Given this list of marker genes Kcnb1 (potassium voltage gated channel, Shab-related subfamily, member 1), Cdr2l, Elovl6, Erc2, Slc30a4, Dcp2, Kcnj3, Lmtk2, Ptprf, Efs, Clcn3, Nlk, Fst, Clvs2, Ppp1r14c, Edem3, Tmem161b, Tlnrd1, Med13, Nfxl1, Tmem151a, Inpp4b, Fcho2, Rnf138, Zcchc14, Dixdc1, Fyb2, E2f4, Gbp10, Vamp2, Arhgap44, Skida1, Gabra2, Calcoco2, Rock2, Spdye4b, Mb21d2, Stc2, Slc16a6, Klf2, Cep43 (centrosomal protein 43), Uros, Col5a1, Rpgr, Abhd13, Hira, Sec14l1, Rbak, Runx2, Zfp654, Eda2r, Kdm7a, Osbpl8, Ell, Lgalsl, Smim13, Gpr183, Kcnj8, Dnajc16, Rala, Bcl2l2, Gtf2h2, Slco5a1, Traf4, Zfp446, Klhl6, Mtmr2, Ror1, Ubox5, Ergic2, C2cd2, Chd1, Cd164, Slc24a2, Matn3, Ntng1, Calcr, Pdp1, Dag1 (NCBI Gene Id 13138), Mfhas1, Npat, Il1r1, Zmiz1 (zinc finger, MIZ-type containing 1), Btaf1, Sptbn4, Cited4, Trim66, Plcl2, Usp9x, Srl, Hspa1l, Flg2, Cplx1, Cramp1, Sox6 (SRY (sex determining region Y)-box 6), Cttnbp2, Zfp267, here is a description of the gene set: Genes predicted to be targets of miRBase v22 microRNA mmu_miR_7578 in miRDB v6.0 with MirTarget v4 prediction scores > 80 (high confidence targets). studied in species Mus musculus from publication Chen Y, Wang X (PMID 31504780) Mouse Gene Set: MIR_7578